Given this list of marker genes Ubb, Tab3, Rps27a, Tab2, Tifa, Tab1, here is a description of the gene set: studied in species Mus musculus electronically inferred by orthology from the curated human pathway This event has been computationally inferred from an event that has been demonstrated in another species.<p>The inference is based on the homology mapping from PANTHER. Briefly, reactions for which all involved PhysicalEntities (in input, output and catalyst) have a mapped orthologue/paralogue (for complexes at least 75% of components must have a mapping) are inferred to the other species. Reactome Pathway: Alpha-protein kinase 1 signaling pathway part of: Innate Immune System